Given this list of marker genes Ctcfl, Dyrk1b, Patj, Eya2, Ago4, Mbd5, Carmil1, Fmn2, Gtpbp1, Agbl5, Zfp367, Bmp2, Tmem222, Zfp521, Klk1, Atg7, Mmgt1, Unk, Snph, here is a description of the gene set: species: Mus musculus Mouse Gene Set: MIR_7064_3P Genes predicted to be targets of miRBase v22 microRNA mmu_miR_7064_3p in miRDB v6.0 with MirTarget v4 prediction scores > 80 (high confidence targets). from publication Chen Y, Wang X (PMID 31504780)